The following is a description of a gene set: Mouse Gene Set: GOBP_ENAMEL_MINERALIZATION The process in which calcium salts, mainly carbonated hydroxyapatite, are deposited in tooth enamel. studied in species Mus musculus, and this is the list of marker genes: Foxo1 (forkhead box O1), Fam20a, Odaph, Dmp1, Fam20c, Cnnm4, Wdr72, Cftr, Tbx1, Ppara, Enam, Nectin1, Slc4a2, Msx2, Amelx, Stim1, Rogdi, Tcirg1, Dspp, Itgb6, Dicer1, Tgfb1, Amtn